The following is a description of a gene set: studied in species Mus musculus from publication Chen Y, Wang X (PMID 31504780) Mouse Gene Set: MIR_1947_3P Genes predicted to be targets of miRBase v22 microRNA mmu_miR_1947_3p in miRDB v6.0 with MirTarget v4 prediction scores > 80 (high confidence targets)., and this is the list of marker genes: Atad1, Zfp800, Slc31a1, Nckap1, Wdr76, Dcc, Dapp1, Mrpl53, Rassf4, Med13, 4930402K13Rik, Ppfia3, Car10, Rbm41, Arhgap19, Dip2c, Bicd2, Cfl2, Vsnl1, Otor, Tmem164, Mbtps2, Rc3h1, Dcp1a, Dnajc27, Plekhh1, Ttc28, 6430571L13Rik, Vasn, Myh10, Cyth1, Ror1, Rab17, Fzd3, Clock, Nr3c1, Zic1, Cdc27, Maml2, Myo18a, Slain2, Sar1b, Arfgef3, Ammecr1l, Rasef, Nsun5, Isx, Rer1, Atrx, Kcns3, Ate1, Pgm2l1, Il15ra, Ubqln2, Larp4, Sprr2f, Gpcpd1, Ddx3x, Taf5, Asxl2, Gucy1a2, Trappc3, Ubap2, Nfat5, Phlpp1, Scn3b, Vgll3, Slc25a36, Rab32, Arpc5, Dsg1b, Gopc, Sestd1, Leprotl1, Zfp119b, Lrba, Card6, Cobl, Efcab14, Slc1a2, Eeig1, Ccn4, Mphosph9, Clta, Atf3, Zbtb34, Tiparp, Hipk3, Mapk1, Itih5, Sec61a1, Xbp1, Ifnar1, Brms1l, Ipmk, Sidt2, Tmem100, Tcf7l2, Tspoap1, Ap3s1, Mtmr3, Rfx1, Agbl2, Stxbp1, Mtcl1, Ccdc71l, Cdkn2c, Zfp28, Ccdc88a, Synpo